The following is a description of a gene set: Mouse Gene Set: GOBP_PHOSPHOLIPID_HOMEOSTASIS studied in species Mus musculus Any process involved in the maintenance of an internal steady state of phospholipid within an organism or cell., and this is the list of marker genes: Lyst, Rcn3, Lipg, Apoa1, Tlcd1, Abca3, Itgb6, Gpam, Abcb11, Abca1, Abcg1, Fabp3, Hnf4a, Slc25a46, Angptl3, Tgfb1, Tlcd2